The following is a description of a gene set: Any cellular process that results in the specification, formation or maintenance of polarized cytoskeletal structures. Mouse Gene Set: GOBP_ESTABLISHMENT_OR_MAINTENANCE_OF_CYTOSKELETON_POLARITY studied in species Mus musculus, and this is the list of marker genes: Nckap1, Pdlim1, Camsap3, Aqp1, Lmna, Ank3, Ckap5, Kif2c, Arhgap35